Given this list of marker genes ALG3, CKAP4, TRIB1, HEXB, CANX, AGA, PLD3 (phospholipase D family member 3), NUCB2, LMAN2, PYGB, RPN2, PRKCI, HSD17B8, NEU1, PLOD1, HSP90B1, SLC35B1, FUT8, HAGH, TRAM2, DUSP7, IL15RA, PDIA5, FGL2, AARS1, HDLBP, TM9SF2, MANF, TRAM1, MAN1A1, ARF4, IGLV1-47, PDXK, IRF4, SPCS2, TMED10, PRDX4, ITGA6 (NCBI Gene Id 3655), IGKC, ICAM2, SELPLG, KDELR2, KDELR1, GAS6, SERPINI1, HYOU1, ARID3A, DDOST, ELL2, SRGN, CD27, SLC7A1, YIF1A, CAV1, GGCX, TNFRSF17, LGALS3, P4HB, CCR2, CD38, EMC2, FKBP2, ANG, NOMO1, SSR1 (NCBI Gene Id 6745), STT3A, RPN1 (NCBI Gene Id 6184), PDIA6, CASP10, HSPA5, IGLJ3, CITED2, SPN, IL6R, PDK1 (NCBI Gene Id 5163), CXCR3, PPIB, PYCR1, SEC61B, SEL1L, AQP3, here is a description of the gene set: species: Homo sapiens from publication Tarte K, Zhan F, De Vos J, Klein B, Shaughnessy J Jr (PMID 12663452) Plasma cells (PCs), the end point of B-cell differentiation, are a heterogeneous cell compartment comprising several cell subsets from short-lived highly proliferative plasmablasts to long-lived nondividing fully mature PCs. Whereas the major transcription factors driving the differentiation of B cells to PCs were recently identified, the subtle genetic changes that underlie the transition from plasmablasts to mature PCs are poorly understood. We recently described an in vitro model making it possible to obtain a large number of cells with the morphologic, phenotypic, and functional characteristics of normal polyclonal plasmablastic cells (PPCs). Using Affymetrix microarrays we compared the gene expression profiles of these PPCs with those of mature PCs isolated from tonsils (TPCs) and bone marrow (BMPCs), and with those of B cells purified from peripheral blood (PBB cells) and tonsils (TBCs). Unsupervised principal component analysis clearly distinguished the 5 cell populations on the basis of their differentiation and proliferation status. Detailed statistical analysis allowed the identification of 85 PC genes and 40 B-cell genes, overexpressed, respectively, in the 3 PC subsets or in the 2 B-cell subsets. In addition, several signaling molecules and antiapoptotic proteins were found to be induced in BMPCs compared with PPCs and could be involved in the accumulation and prolonged survival of BMPCs in close contact with specialized stromal microenvironment. These data should help to better understand the molecular events that regulate commitment to a PC fate, mediate PC maintenance in survival niches, and could facilitate PC immortalization in plasma cell dyscrasias. Genes up-regulated in plasma cells compared with B lymphocytes. Human Gene Set: TARTE_PLASMA_CELL_VS_B_LYMPHOCYTE_UP